The following is a description of a gene set: The series of molecular signals initiated by a signaling molecule binding to an intracellular receptor of the nuclear receptor protein family, and ending with regulation of a downstream cellular process, e.g. transcription. Mouse Gene Set: GOBP_NUCLEAR_RECEPTOR_MEDIATED_SIGNALING_PATHWAY studied in species Mus musculus, and this is the list of marker genes: Safb2, Trim24, Dnaaf4, Rara, Hmga2, Ncoa3, Ufl1, Cyp7b1, Crkl, Cyp26b1, Ddx5, Ncoa2, Foxa1, Ppp5c, Calcoco1, Brca1, Huwe1, Aloxe3 (NCBI Gene Id 23801), Kdm5d, Lats1, Sp1, Alox8, Skp2 (NCBI Gene Id 75034), Greb1l, Calr, Snw1 (NCBI Gene Id 66354), Nr3c2, Tgif1, Taf7, Phb2, Rxrg, Ywhah, Sirt1 (sirtuin 1), Foxh1, Ghrhr, Park7, Fshr, Scgb2a2, Fabp5, Klf9, Sfrp1, Esrra, Parp1, Pml, Padi2, Srarp (steroid receptor associated and regulated protein), Rbfox2 (RNA binding protein, fox-1 homolog (C. elegans) 2), Ctbp2, Akr1c18, Zdhhc7, Mn1, Ptges3, Thrb, Pdk3, Ar, Pgr, Clock, Prmt2, Cnot3 (CCR4-NOT transcription complex, subunit 3), Cyp2j6, Usp26, Tcf21, Tmf1, Shq1, Src, Abhd2, Paqr3 (progestin and adipoQ receptor family member III), Stub1, Prcp, Akap13, Isl1, Cst11, Cnot1 (NCBI Gene Id 338501), Asxl1, Pagr1a, Gprin3, Ncor2, Asxl2, Esr1, Igf1, Dab2, Actn4, Gh, Rxra, Dhrs3, Pparg, Klf2, Fam120b, Trim68, Jund, Rarb, Wbp2, Stard10, Vps18, Gper1, Zmiz1, Nkx3-1, Alox15, Plin5, Safb, Ddx17, Esr2, Rhoa, Lep, Cyp26a1, Mapk1, Ufsp2, Rwdd1, Esrrg, Nr2c1, Errfi1, Pak1, Dnaja1, Bmal1, Hmga1, Zbtb7a, Aldh1a3, Nr3c1, Ptgis, Zfp366, Ppara, Nr1h4, Crebrf, Ufm1, Rnf6, Kdm4c, Bmp2, Ezh2, Vdr, Pim1, Ube3a, Lmo3, Pde3a, Kmt2d, Jak2, Arid1a (AT-rich interaction domain 1A), Lbh, Nr1h2, Pten, Strap, Hdac1, Uba5, Rarg, Cnot9, Strn3, Per1, Twist1, Nedd4, Cited2, Tbx1, Or51e2, Nr0b1, Thra, Cnot2, Foxp1, Ntrk2, Med1, Trerf1, Fkbp4, Ddrgk1, Zfp536, Bdnf, Ubr5, Ep300, Gphb5 (glycoprotein hormone beta 5), Ppargc1b, Ncor1, Rnf14, Pias2, Aldh1a2, Daxx, Pou4f2, Kdm3a, Cry1, Ncoa1, Smarca4, Nodal, Vps11, Snai2, Rxrb, Cyp27b1, Trip4, Carm1, Kank2 (KN motif and ankyrin repeat domains 2), Trp63, Esrrb, Heyl, Gps2, Kmt2e, Ptf1a, Cry2, Phb1